The following is a description of a gene set: from publication Tesar PJ, Chenoweth JG, Brook FA, Davies TJ, Evans EP, Mack DL, Gardner RL, McKay RD (PMID 17597760) species: Mus musculus Genes up-regulated in EpiSC cells (epiblast stem cells) after treatment with the ALK inhibitor SB-431542. The application of human embryonic stem (ES) cells in medicine and biology has an inherent reliance on understanding the starting cell population. Human ES cells differ from mouse ES cells and the specific embryonic origin of both cell types is unclear. Previous work suggested that mouse ES cells could only be obtained from the embryo before implantation in the uterus. Here we show that cell lines can be derived from the epiblast, a tissue of the post-implantation embryo that generates the embryo proper. These cells, which we refer to as EpiSCs (post-implantation epiblast-derived stem cells), express transcription factors known to regulate pluripotency, maintain their genomic integrity, and robustly differentiate into the major somatic cell types as well as primordial germ cells. The EpiSC lines are distinct from mouse ES cells in their epigenetic state and the signals controlling their differentiation. Furthermore, EpiSC and human ES cells share patterns of gene expression and signalling responses that normally function in the epiblast. These results show that epiblast cells can be maintained as stable cell lines and interrogated to understand how pluripotent cells generate distinct fates during early development. Human Gene Set: TESAR_ALK_TARGETS_EPISC_4D_UP, and this is the list of marker genes: TUBB3, DCX, ZIC1, MSX1, PAX6, NES